The following is a description of a gene set: studied in species Homo sapiens Facial hyperostosis Human Gene Set: HP_FACIAL_HYPEROSTOSIS Excessive growth (overgrowth) of the facial bones, that is of the facial skeleton., and this is the list of marker genes: PTDSS1, AMER1, GJA1, SOST, AKT1